Given this list of marker genes a, Ap1s1, Ap1s3, Ap1m1, Bace2, Bloc1s5, Hps1, Rab29, Ap3d1, Pmel, Rab32, Bloc1s3, Hps6, Kif13a, Bcl2, Ap3m1, Tyrp1, Bloc1s6, Hps4, Hps3, Rab38, Bloc1s4, Ap1s2, Pikfyve, Dtnbp1, Snapin, Apoe, Ap3s2, Ap3b1 (NCBI Gene Id 97864), Ap3s1 (adaptor-related protein complex 3, sigma 1 subunit), Zeb2, Ap1g1, Shroom2, Bloc1s2, Ap1b1, Hps5, Bloc1s1, Lyst, Gpr143, Abcb6 (ATP-binding cassette, sub-family B member 6), here is a description of the gene set: species: Mus musculus Mouse Gene Set: GOBP_PIGMENT_GRANULE_ORGANIZATION A process that is carried out at the cellular level which results in the assembly, arrangement of constituent parts, or disassembly of a pigment granule.